Given this list of marker genes Fgf4, Fgf6, Fgf16, Fgf2, Fgf15, Fgf20, Fgf8, Klb, Fgf1, Fgf23, Fgf17, here is a description of the gene set: Reactome Pathway: FGFR4 ligand binding and activation part of: Signaling by FGFR4 This event has been computationally inferred from an event that has been demonstrated in another species.<p>The inference is based on the homology mapping from PANTHER. Briefly, reactions for which all involved PhysicalEntities (in input, output and catalyst) have a mapped orthologue/paralogue (for complexes at least 75% of components must have a mapping) are inferred to the other species. species: Mus musculus electronically inferred by orthology from the curated human pathway